The following is a description of a gene set: studied in species Homo sapiens Human Gene Set: GOCC_RNA_POLYMERASE_II_TRANSCRIPTION_REPRESSOR_COMPLEX A protein complex, located in the nucleus, that possesses activity that prevents or downregulates transcription from a RNA polymerase II promoter., and this is the list of marker genes: LIN54, CTNNBIP1, TBX18, CTNNB1, MAX, FOXO3, MYC, DDX20, DRAP1, MXD1 (MAX dimerization protein 1), DR1, TBX15, ETV3, LIN52, BIN1